The following is a description of a gene set: Mouse Gene Set: GOBP_TRICUSPID_VALVE_DEVELOPMENT The progression of the tricuspid valve over time, from its formation to the mature structure. species: Mus musculus, and this is the list of marker genes: Zfpm2 (NCBI Gene Id 320725), Zfpm1, Hey2, Bmpr1a, Adamts19, Bmpr2, Tbx20, Tgfbr2, Gata4